Given this list of marker genes NKX3-2, CTBP1, COG4, LETM1, FGFRL1, RAB23 (RAB23, member RAS oncogene family), NPR3, KCNH1, SALL1, PCNT, CPLX1, RPS6KA3, GDF5, ERI1, NSD2, BMPR1B, here is a description of the gene set: Human Gene Set: HP_PSEUDOEPIPHYSES_OF_HAND_BONES Pseudoepiphyses of hand bones species: Homo sapiens